Given this list of marker genes EPHA8, FFAR4, ZXDC, SLC44A5, USP49, here is a description of the gene set: species: Homo sapiens Human Gene Set: MIR4638_5P Genes predicted to be targets of miRBase v22 microRNA hsa-miR-4638-5p in miRDB v6.0 with MirTarget v4 prediction scores > 80 (high confidence targets). from publication Chen Y, Wang X (PMID 31504780)